The following is a description of a gene set: studied in species Homo sapiens A reproductive process occurring in the embryo or fetus that allows the embryo or fetus to develop within the mother. Human Gene Set: GOBP_EMBRYONIC_PROCESS_INVOLVED_IN_FEMALE_PREGNANCY, and this is the list of marker genes: JUNB, CITED2, ACSL4, HSF1, SP3, EMP2, TLE6, NODAL